The following is a description of a gene set: from publication Yevshin I, Sharipov R, Kolmykov S, Kondrakhin Y, Kolpakov F (PMID 30445619) Human Gene Set: TAFAZZIN_TARGET_GENES Genes containing one or more binding sites for (TAFAZZIN) in their promoter regions (TSS -1000,+100 bp) as identified by GTRD version 20.06 ChIP-seq harmonization. studied in species Homo sapiens, and this is the list of marker genes: CIMIP2C, SLC7A6 (solute carrier family 7 member 6), NRGN-AS1, RPGR, GLIPR1L2, LINC02695, IDH3B-DT, CXCR4, FSCN2, H3C9P, EPOR, SUPV3L1, HPCA, TMEM170A, SOCS3 (suppressor of cytokine signaling 3), HMCN1, AHNAK, RFX2 (regulatory factor X2), DNMT3A, PEF1, DKK1, GPNMB, ENSG00000266100, H3P42, VAC14, ANKS6, UBFD1, CAMTA2, SELENOW, PAX5, IDH3B, ALDH2 (aldehyde dehydrogenase 2 family member), CSK, SNRPA1, NCKAP1, CPNE2-DT, EXOC3L4 (exocyst complex component 3 like 4), SH3BP4 (SH3 domain binding protein 4), AATBC, RAP2C, SERTAD2, TMOD1, DIS3L (NCBI Gene Id 115752), AJUBA-DT, LINC00466, ZNF417, PKMYT1, DEAF1 (NCBI Gene Id 105376508), EDN1, GALK1 (galactokinase 1), DAB2, SHROOM3, CAPS2, RPIA, MTHFR, NR1H3, C15orf62, ZFYVE28, GAR1, TIMM44, CEP85, SAMD10, EIF2AK1, TMEM179B, ITM2C, STK17A, SAP30BP-AS1 (NCBI Gene Id 128667226), CMTM3, FRMD6, SRF, RNF39, DEDD, LRP6, TEPSIN, ETV4, ARHGEF17-AS1, ADSS1, ENSG00000268460 (NCBI Gene Id 93429), POLR3G, IL17RB, TEAD1, SLCO3A1, RRP12, SRSF10, SNHG16, ZCCHC4, POGK, STARD10, TSC2, PKP4-AS1, ING4, SRI (NCBI Gene Id 6717), BATF3, CBX4, ADNP, CCDC124, USF2 (NCBI Gene Id 7392), RN7SL736P, PRPF40B, H3P1, ESAM-AS1, KCTD11, LEMD2, ARHGAP28-AS1, HARBI1, ENSG00000267288 (novel transcript, antisense to HEXIM2), CES3, DST, ENSG00000272473, MYL12-AS1, AJUBA, DNAH2, ALG3, PRKACA, NXPH3, DDN, PLEC, SIRT2, RPL32P3, TFAP2C, CHDH, P4HTM, GUSBP2, PDE4A, ANKRD63, YBX3, PCOLCE-AS1 (PCOLCE antisense RNA 1), CASKIN2, TFR2, PITPNC1, COX20, GAR1-DT, SLC4A8 (NCBI Gene Id 9498), SPEG, LINC01842, RPAP2, TGFB1I1, TBC1D4, MYL12B, H3P40, ZSCAN29, HHAT, EPS8L1, CDK6, NME2, CLCN6, VEPH1, TBC1D22A, RORA, KSR1, CCDC88B, IGFL2-AS1, TP53I3, EIF1B (eukaryotic translation initiation factor 1B), SGPL1, CRY1, TERF2, LTBP1, BRD9P1, SYNJ2, MAP3K15, OSGEPL1, NOL4L, BEND6, ARAP1, REEP5, CACNB3, CUX1, CAPN2, PHLDB1, MOV10L1, LINC01836, PIGW, GSTP1, CEACAM7, STX16, MEST, DOCK8, PTPN11, RN7SKP192, CLPB, FAM186A, MYBBP1A, SNHG21, CYREN, GPI, CCDC9B, ISG20, RHOG, ZNF423, MED13, PLXNB2, PRKAB1, SNORC, CBLN3, MARCHF7 (NCBI Gene Id 64844), ITGB5, MYO19, SH2B3, KHNYN, CEACAMP2, PPP1R26, PCOLCE, ENSG00000239137, G6PC3, LZTS2, SMIM13, RAB11FIP4, PRR11, AVPR1B-DT, PEF1-AS1, CENATAC, MIR7155, CYB561D1, DSCR9, PARP1, JUP, MIR298, ATXN2, ASXL1, CDH24, CORO6, CDC42EP4, LINC01203, CFAP99, SAMD4A, ARHGAP28, CCT6P3, TMT1B, SMURF2P1, ZC3H7A, ZZEF1, TMEM86A, PKP4, TPGS2, CORO1A, FOXO6, FLT3LG, MYO15B, VEGFA, SARS2, CHD8, SYDE2 (NCBI Gene Id 84144), POLR2D, CLDN6 (claudin 6), OTUD4, NOTCH1 (NCBI Gene Id 54781), CDS2 (NCBI Gene Id 96708), DYNC2I2, ODAD1, CEACAM1, FER, DHX34, TOGARAM2, LINC00240, CXADR, FKBP14-AS1, SLC39A1, RN7SL674P, PLCB3, ESAM, C9, RRAS, TNNT1, NOX4, CCDC85C, FXYD5, TK1, EXD3, ERBB3, COL8A2, PDZD7, FKBP7, ZNF385C, MIDN, EFNA5 (ephrin A5), RPS6KA1, TJP2, ZBTB39, ADAMTSL5, NALT1, MICB, LINC01937, MAP6D1, PGAM1, ENSG00000201003, NUB1 (negative regulator of ubiquitin like proteins 1), OSGEPL1-AS1, ACP1, NR4A1, H3-3A-DT, ZNF638, BIRC2, ATL2, FMN1, SRCIN1, EML6 (NCBI Gene Id 649652), RNU1-8P, PFDN4, SPHK1, LINC01186, SCN5A, ZBTB34 (zinc finger and BTB domain containing 34), TXNRD2, MYLK-AS1, H3P44, ROM1, ARHGEF39, CRY2, STRA6, TRIB3, LINC01843, SAE1, SKA2, FSD1L, RPL39P40, ZNF792, DNAAF3, MIEN1, LINC02585, DIDO1, BCAN-AS2, DRAIC, LRIG2, ENSG00000223343, HACD2, CACNA2D4, LINC01672, L1CAM, LSP1, FAM83D, ENSG00000227496, SNX8, EIF5A2, MELTF, LRIG2-DT, SH3D21, RASAL1, UNC5CL, SYT8, EIF1B-AS1, NOXA1, PPP1R3E (protein phosphatase 1 regulatory subunit 3E), H3P28, RAPGEF3, ABCA2, GPR3, SLC4A8-AS1, ENSG00000225676, GCLC, MRPL34, CYP2E1, PLXNB3, PIGS, CDK11A (NCBI Gene Id 986), BICDL3P, MIR22HG, AXL, SFN, CABIN1, UBE2O, PSG1 (NCBI Gene Id 91730), RELT, TTYH2, ANKRD9, EHD1, ADAMTS8 (NCBI Gene Id 11095), GPER1, MGRN1, PARVA, HCG20, CBX2, LINC01389, ALDH3B1, VPS72, ARTN, CNN3, MAFK, TRIB2, MRPS9-AS1, PTPN14, HPS4, KRT8, PPP2R5A (NCBI Gene Id 5525), CEP112, PDSS2, HOXA1, LAMTOR2, MAP2K3, ZBTB4, AVPI1, PCNA, SPINK2, PIR, NFKBIB, HOOK2, CHRNB1, MAB21L4, AFMID, GRHL1, SYT12, SLC37A4, CHD2, SEPTIN9, ZBTB45, SMTN (NCBI Gene Id 6525), ATAT1, BCAM, PAQR4 (NCBI Gene Id 124222), HOTAIRM1, GPAT4, ITGA3, H3-3A, SNHG26, POLR3A (NCBI Gene Id 11128), AVPR1B, CATSPERG, CENATAC-DT, CELSR3, GNA11, PDXK (pyridoxal kinase), PRPF6, RIOK3, MBLAC2, MRPS12, AMOTL2, AANAT (aralkylamine N-acetyltransferase), FOXL2, STMN1, BBC3, THBS1, METTL21A, SYMPK, NAPA-AS1, NDUFA4, CRABP2, TSEN54, FAM222A, RAB8A, LMNA, PRKG1-AS1, ANKRD1, STX16-NPEPL1, WT1-AS, PIWIL2, CELSR1, BNIP1, CDK6-AS1, LEMD1, ZDHHC8, NDUFAF8, RBBP5, LINC01775, LNCRNA-IUR, NTHL1, CRACR2A, RDH13, COL16A1, LINC02004, FOXL2NB, CGB1, THEM4, HOXA-AS2, RPL36, RASGRP2, ZNF217, RPL6, LINC01968, EML3, LTBP2, KIAA1328, PITX3 (paired like homeodomain 3), MBD6, LINC02251, LRRC3-DT, MCAM, UBQLN4, MMP19, LINC01275, KPTN, EARS2, CRYBG1, TCAM1P, TGFBI, CST5, SEPTIN9-DT, ESPN